The following is a description of a gene set: Binding to chromatin, the network of fibers of DNA, protein, and sometimes RNA, that make up the chromosomes of the eukaryotic nucleus during interphase. studied in species Mus musculus Mouse Gene Set: GOMF_CHROMATIN_BINDING, and this is the list of marker genes: Dlx3, Scmh1, Mnt, Mbd1, Pwwp2a, Smc1a, Faap24, L3mbtl3, Ajuba, Dlx1, Nkx2-5, Nelfa, Chd6, Zfp110, Rcc1, Sirt6, Phc3, Zfp683, Noc3l (NCBI Gene Id 57753), Nfe2l1, Adnp, Rpa1, Bmi1 (NCBI Gene Id 12151), Pold1, Pou1f1, Hmga1, Chd8, Mbd6, Ssrp1, Tox3, Sall1, Trp53, Satb1, Rad21l, Brip1, Bcas3, Prdm11, Cdt1, Ubtf, Slc30a9, Arid5a, Csnk2b (casein kinase 2, beta polypeptide), Nsd2, Tbr1, Ppp2r3d, Chd1l, Zkscan3, Kat7, Ncaph2, Bap1, Zfp932 (zinc finger protein 932), Zfp445, Hnf4a, Ruvbl2, Fcor, Rnf2, Nup98, Mbd5, Pygo2, Wac, Wbp2nl, Rad51, Yap1, Tasor (NCBI Gene Id 74444), Elk1, Sirt1, Rag2, Cramp1, Tspyl5, Ticrr, Ring1, L3mbtl2, Hdac1, Cbx1, Nrl, Phf13, Zfp369, Suz12, Hells, Kat8, Msgn1, Tspyl4, Rbpjl, Smarca1, Smarcad1, Tspyl1, Grwd1, Evx1os, Polr2b, Polg, Kdm6b, Kdm4d, Tcf4, Hhex, Tfap2b (NCBI Gene Id 98405), Dhx30, Trim66 (tripartite motif-containing 66), Hmgn2, Notch1, Srf, Neurog3 (neurogenin 3), Gtf2b, Prdm14, Tal1, Grhl3, Hdgfl3, Smarca2, Insm1, Dlx2, Eny2, Egr1, Hnrnpd, Rxra, Top2b, Scml2, Trim28, Foxn4, Wdr82, Nr3c1, Ift74, Arid1b, Dnmt1, Kcnq1ot1, Msl2, Ash1l, Nr1h2, Ehmt2 (euchromatic histone lysine N-methyltransferase 2), Samd1, Prkaa2, Tfap2a, Ybx1, Per1, Paupar, Taf10, Actr6, Crtc2, Wdhd1, Ikzf5, Ccnt1, Hsf1, Skor2, Runx2, Prkaa1, Nfat5, Zeb1 (NCBI Gene Id 73165), Trim24, Tcf3, Pbrm1, Sbno1, Pax6, Chd7, Ep300, Foxo1 (NCBI Gene Id 99758), Acss2, Ctbp2, Phf21a, Fezf2, Foxa2, Cited1, Mcm3ap, Mybl1, Noc2l, Thrb, H1f8, Sfmbt1, Rbpj, Polr3g, Ttc21b, Rad17, Vrk1, Lcor, Mef2a, H2az1, Dnttip1, Ncoa6, Trp63, Camta2, Nap1l2, Svep1, Apex1, Rbmxl1, Rbl2 (NCBI Gene Id 19651), Foxa1, Sap30l, Hpf1, Prkcb, Nap1l3, Zfp143, Hoxd13, Kmt5b, Uri1, Srebf2, H1f1, Tdrd3, Ssbp1, Ncaph, Chd5, Mir208b (NCBI Gene Id 100124433), Smarcd3, Mllt6, Isl1, H3f3b, Setd7, Primpol, Chd1, Wdr13, Usp3, Bcl6, Rest, Ctbp1, Smarcc2, Tpr, Tgif1, Ddx17, App, Rnf8, Jun, Ncoa5 (nuclear receptor coactivator 5), Brca1, Sf3b1, Mcm8, Prdm13, Med12, Fus, Rela, Nfatc1, Klf14, Gtf2h1, Nfatc2, Cbx3, Nap1l4, Polr3gl, Dppa2, Pou4f2, Clock, Mta3, Actl6a (NCBI Gene Id 99742), Nup153, Tspyl2 (TSPY-like 2), Jmjd1c, Nudt21, Nkx6-1, Nap1l1 (nucleosome assembly protein 1-like 1), Bhlhe22 (NCBI Gene Id 59058), Erg, Meis1, Lmo2, Vax1, Fmr1 (fragile X messenger ribonucleoprotein 1), H1f2, Akap8, Gabpa, Dnajc2, Yy1, Hes5, Taf5, Pou4f1, Tada2a, Rarg, Nfia, Chd2, Zfp354b, Wrn, Mitf, Cbx6, Kdm8, Klhdc3, Dhx9, Obi1, Chd3, Aire, Gata1, Rnf169, Hinfp, Ezh1, Zfp276, Fli1, Sox15, Sarnp, Foxp1, Macroh2a2, Grhl1, Foxc2, Supt6, Cdk1, Hsf3, Hnf1a, Gli3, Eya3, Epop, Orc1, Mlh3, Mta1, Mexis, Stpg4, Fosl2, Ankrd17, Thra (thyroid hormone receptor alpha), Tox4, Pole3, Cbfa2t3, Myod1, Coq7, H1f0, Cenps, Msh2, Kdm3b (KDM3B lysine (K)-specific demethylase 3B), E2f4, Atf5, Mcmbp, Mapk15, Prdm8, Ncoa2, Cgas, Sin3a, Phf10, Smad4, Med1, Calcoco1, Hoxd10, Ski, Pclaf, Stat5b, Polq, Cenpb, Cbx2, H3f3a, Taf2, Brd2, Morf4l1, Nr5a2, Ddx11, Gtf2f1, Smad2, Atad2, Npm1, Eed, Ddx5, Gata6, H1f9, Ctcf, Ttf1, Gmnn, Gata4, Ncoa3, Taf1, Atf4, Kdm3a, Cebpb, Ybx2, Sbno2, Plac8, Rbl1, Pitx2, Atrx (NCBI Gene Id 67403), Paf1, Shmt2, Smarca5 (NCBI Gene Id 93762), Pus1, Kdm6a, Phc1, Nucks1, Atoh1, Actl6b, Zfp386, Dmrt1, Neurod1, Samd7, Hira, Smarca4, Pcbp2, Phf8, Nanog, Atxn7, Egr2, Hnrnpu, Sox2, Ptf1a, Hdac4, Meiob, Ebf2, Pcgf2, Phf19 (NCBI Gene Id 76981), Uxt, Rxrb, Top1, Foxo3, Arid3c, Barx2, Fabp1, Brd3, Cebpa, Stag2, Meox1, Kat6b, Cited2, Macroh2a1, Aptx (NCBI Gene Id 66408), Zfp692, Asxl3 (NCBI Gene Id 399610), Tcf7l1, Kdm1a, Ctnnb1, Ddx1, Ing5 (inhibitor of growth family, member 5), Twist2, Arid3a, Eomes, Kat5, Zfp57 (zinc finger protein 57), Onecut1, Ercc4, Stag1, Lrwd1, Prdm1, Sox9, Znhit1, Hesx1, Ercc3, Pax3 (paired box 3), Ar (androgen receptor), Pdx1, Hmgn5, Bahd1, Trim37, Mta2, Msh6 (NCBI Gene Id 17688), Gadd45a, Tada2b, Phc2, Dppa4 (developmental pluripotency associated 4), Nsd1, Kmt2a, Smc4, Mtf2, Arid1a, Ube2t (NCBI Gene Id 96904, ubiquitin-conjugating enzyme E2T), Rara, Dnmt3b, Sirt7, Trim33, H1f5, Hdac2, Ttc5, Tox, Mecp2, Ncor2 (nuclear receptor co-repressor 2), Hes1, Hr, H1f3, Cys1, Rad21, Lhx2, Setdb1, Egfr, Stag3, Samd11, Nfatc3, Hdac3, Parp2, Gmnc, Grhl2, Scml4, Actn4, Pparg, Hdac7, Men1, Sox14, Irf3, H1f6, Uty, Exo1, Arx (NCBI Gene Id 11878), Hdac5, Atf2, Ogt (NCBI Gene Id 77137), Mbtd1, Pcna, Brd4, Stat1, Hmgn1, Npm3, Sfpq, Cdc6, Kat2b, Ercc1, Asxl1, H1f10, Ldb1, Zfp750, Ep400, Ascl1, Neurog1, Upf1, Crebbp, Nfix, Sfmbt2, L3mbtl4, Fancm, Smarcc1, Kmt5c, Mkrn1, Hdac8 (histone deacetylase 8), Atad2b, L3mbtl1, Nkap (NCBI Gene Id 67050), Actrt1, Sirt2, Nono, Auts2, Myog, Tnrc18, Nupr1, Nelfe, Mphosph8, Mbd2, Creb3, Rbmx, Sp3, Nipbl, Cbx5, Snai2, Rnf4, Ankrd2, Supt16, Ikzf3, Prmt6, Lemd2, Rnf20, Ncoa1, Cdc45, Six1, Glyr1 (NCBI Gene Id 74022), Ecsit, Esr1, Dnmt3a, Tshz3, Elk4, Zfx (zinc finger protein X-linked), Sox10, Nfkb1, Wbp2, Ovol2, Lemd3, Tle4, Fosl1, Polr1a, Pwwp3a, Cks2, Tcf7l2, Usp51, Rcor1 (NCBI Gene Id 28079), H1f4, Skil, Rit2, Smad6, Pkn1, Hmga2, Psip1, Foxc1, Zic2, Pou2f1, Patz1, Stat3, Pbx2 (pre B cell leukemia homeobox 2), Repin1, Morc2b, Mrnip (NCBI Gene Id 72859), Ppargc1a, Cic, Pole, Meis3, Crx, Pou5f1, Zc3h4, Creb3l1, Cux1, Tox2, Hcfc1, Gli1, Jdp2, Klf4, Smad3, Prop1, Cbx4, Bahcc1, Smc2, Morc2a, Vax2, Ndn, Kat6a, Atxn1l (ataxin 1-like), Ahdc1, Zfp609, Maz, Jarid2, Tspyl3, Suv39h2, Cbx8, Mllt10, Nr5a1, Zfp125, Asxl2, Npm2, H3c14, Apbb1 (NCBI Gene Id 11785), Ncor1, Nkapl, Polr3a, Lef1, Nr1h3, Srebf1, Asf1a, Safb, Tle1, Parp1, Pelp1, Cdyl, Hp1bp3, Xbp1, Runx1, Hnf1b, Supt5, Gli2, Kat2a, Ccnt2, Polr3d, Smarcd1, Pcgf1, Gata2, Spi1, Hmgn3, Esr2, Kdm5a, Ezh2 (NCBI Gene Id 14056), Foxo4, Gm20379, H3f5, Mllt3 (myeloid/lymphoid or mixed-lineage leukemia; translocated to, 3), Ttc39aos1, Prmt5, Zc3h12a, Mcm9, Hoxc13, Satb2, Mllt1, Sin3b, Chd4, Phf1, Parg, Gper1, Cbx7, Pola1, Cdk9, Atrn, Tbl1x, Rere, Cabin1, Polr2a, Ercc6, Ctcfl, Set, Rnf168, Fos, Top2a, Prdm15, Mef2c, Smc3, Bend6, Rec8, Kdm4c, Tfam, Pknox1, Mlh1, Atxn1